The following is a description of a gene set: Genes down-regulated in MEF cells (embryonic fibroblast) with ELAVL1 knocked out. HuR is an RNA-binding protein implicated in a diverse array of pathophysiological processes due to its effects on the posttranscriptional regulation of AU- and U-rich mRNAs. Here we reveal HuR's requirement in embryonic development through its genetic ablation. Obligatory HuR-null embryos exhibited a stage retardation phenotype and failed to survive beyond midgestation. By means of conditional transgenesis, we restricted HuR's mutation in either embryonic or endothelial compartments to demonstrate that embryonic lethality is consequent to defects in extraembryonic placenta. HuR's absence impaired the invagination of allantoic capillaries into the chorionic trophoblast layer and the differentiation of syncytiotrophoblast cells that control the morphogenesis and vascularization of the placental labyrinth and fetal support. HuR-null embryos rescued from these placental defects proceeded to subsequent developmental stages but displayed defects in skeletal ossification, fusions in limb elements, and asplenia. By coupling gene expression measurements, data meta-analysis, and HuR-RNA association assays, we identified transcription and growth factor mRNAs controlled by HuR, primarily at the posttranscriptional level, to guide morphogenesis, specification, and patterning. Collectively, our data demonstrate the dominant role of HuR in organizing gene expression programs guiding placental labyrinth morphogenesis, skeletal specification patterns, and splenic ontogeny. species: Mus musculus from publication Katsanou V, Milatos S, Yiakouvaki A, Sgantzis N, Kotsoni A, Alexiou M, Harokopos V, Aidinis V, Hemberger M, Kontoyiannis DL (PMID 19307312) Mouse Gene Set: KATSANOU_ELAVL1_TARGETS_DN, and this is the list of marker genes: Pitx1, Clmp, Dhfr, Adgrg2, Snord34, Tcf19, Gm9847 (NCBI Gene Id 217403), Gzmd (NCBI Gene Id 14941), Mybl2, Col6a1, Cyp4a12a, Npnt, Dkc1, Sgk1, Fam131b, Haus7, Fgl2 (NCBI Gene Id 14190), Slc19a1, Troap, Anxa8, Siglecg, Aldh7a1, Gstm1, Dynap, Pde8a (phosphodiesterase 8A), Ube2c, Pwp2, Fhl3, Timeless, Hoxd11 (homeobox D11), Shmt1, Tcof1, Ramp3, H2-M9, Bmal1, Ccbe1, Aebp1, Kif18b, Cxcl5, St3gal6, Mcpt8, AW551984, Ets2, Ifi204, Cxcr4, Eps8, U90926, Nolc1, Pfas (phosphoribosylformylglycinamidine synthase (FGAR amidotransferase)), Serpinb2, Nsrp1, Hmgn5, Ttc7, Slco2a1, Flt4, Col5a3 (collagen, type V, alpha 3), Pdgfra, Fanca, Med18, Vegfd, Dusp10 (NCBI Gene Id 98270), Depdc1a, Mphosph6, Tfap4, Col6a2, Fam185a, Sgcd, Wnt2, Fmnl2, Asb5, Fgf10, Steap1, Sfrp2, Efcab7 (NCBI Gene Id 381610), Abtb3, Pak1, Tgfbr3, Layn, Kif5c, Incenp (inner centromere protein), Adamts9, Avpr1a, Ank3, Angptl2, Armc6, Inhbb, Stxbp4 (syntaxin binding protein 4), Osmr, Igfbp4, Pcp4l1, Fus, Lama2, Igsf10, Prg4, Cyp4a12b, Tgfbi, Thbs4, Edil3, Ddx23, Fosl1, Ppbp, Fpgs, Foxf2, Tmem45a, Hoxd13, Rnf181, Coch, Pus7, Mettl13, Hrob, Clip4, Iqgap2, Ggt7, Grb14, Plxnc1, Eml3, Sbspon, Tnpo2, Nmnat2, E330013P04Rik, Etv4, Tep1, Cdca7l, Rrp12, Cd44, Cdr2l, Zfp213, Tiam1, Fbn2, Pus7l, Tbx4, Ccnyl1, Mns1, Klhdc8a, Dlst, Casp12, Rab39b, Cdh3 (cadherin 3), Mgll, Fst, Il1rl1, Chd1l, Pkmyt1, Rogdi, Nedd4l, Stk38 (serine/threonine kinase 38), Hycc1, Rint1, Stmn2, Tnn, Gjb2, Gjb3, Pkdcc